Given this list of marker genes NME5, TGFBR1, OFD1 (NCBI Gene Id 8481), TRHR, SLC25A20, DNAH11, GJA1, ZIC2, FUZ (NCBI Gene Id 80199), OCRL, TGFB2, LBR, GDF15, HELLPAR, DNAAF11, FOXH1, DNAH9, CFI, MYLK, DNAAF3, SMAD3, PRKG1, CYP11B1, PTCH1, PROKR2, CFAP300, IARS1, CD46, ADGRG6, PROP1, DNAJB13, TSHB, SPTBN1, SPAG1, MCIDAS (NCBI Gene Id 649510), NUAK2, RSPH9, ASH1L, HBA2, PAH, DLL1, ABCC6, FOXJ1, SYCP3, HYMAI, THSD4, PLAGL1, CFAP221, MME, TP63, CRB2, TGFB3, VANGL1, INTS11, ANXA5, SLC5A5, CDON, CYP11A1, ODAD4, SHH, ODAD2, HYDIN, CFH, ITGB4, DISP1, DNAH1, SERPINC1, ACTA2, RSPH1, F5, TOP6BL, FGF8, DNAAF5, FDXR, TSHR, HESX1, DNAAF6, GAS2L2, MAT2A, SPEF2, FGFR1, CCDC39, ABCB11, ABCB4, PPARG, DNAI1, DNAL1, STK36, DNAAF2, SOX3, SLC35A2, SPINK1, TPO, NOS3, FOXE3, DRC1, MTHFR, MSX1 (NCBI Gene Id 4487), GLI2, LHX4, CCNO (NCBI Gene Id 9998), SMAD4, F2, DUOXA2, HNF1A, CRIPTO, LMNA, LRRC56, CLCNKB, POR, MYT1L, DUOX2, NR1H4, CTRC, MYH11 (myosin heavy chain 11), KCNJ11, STOX1, RSPH4A, NAA10, DNAH5, PLEC, SUFU, COL2A1, CPT1A, NME8, ENPP1, DHPS, F13A1, SIX3, SMAD2, LOX, HEY2, F12, FCGR3B, ABCC8, NKX2-5, SOX2, CYP19A1, CFAP74, POU1F1, DNAI2, RNF13, CORIN, ODAD3, DNAAF4, LHX3, CCDC40, ODAD1, NLRP7, ZMYND10, RPGR, ZFP57, DNAAF1, GAS1, FBN1, EP300, TG (thyroglobulin), OTX2, IRF6, RSPH3, TGIF1 (TGFB induced factor homeobox 1), HBA1, F13B, NR3C2, ATP8B1, MFAP5, NECTIN1, HADHA, CYP11B2, TGFBR2, NEK10, ARNT2, CFAP298, NODAL, SLC12A3, IYD, ELN, VANGL2, HTR1A, TTC12, here is a description of the gene set: Past medical history studied in species Homo sapiens In a medical encounter, the physician generally will interview the patient about his or her current problem, and may perform additional testing. The past medical history (PMH) in contrast records information about the patient's medical, personal and family history that might be relevant to the presenting illness or to provide optimal clinical management. The PMH generally includes (if relevant) other major illnesses, hospitalizations, surgeries, injuries, allergies, gynecologic and obstetric history, family history, personal history including occupational history, alcohol and drug use, etc. Human Gene Set: HP_PAST_MEDICAL_HISTORY